The following is a description of a gene set: studied in species Homo sapiens Catalysis of the hydrolysis of any non-peptide carbon-nitrogen bond in a linear amidine, a compound of the form R-C(=NH)-NH2. Human Gene Set: GOMF_HYDROLASE_ACTIVITY_ACTING_ON_CARBON_NITROGEN_BUT_NOT_PEPTIDE_BONDS_IN_LINEAR_AMIDINES, and this is the list of marker genes: DDAH2, ARG1, ARG2 (NCBI Gene Id 384), PADI1, PADI6, DDAH1, PADI3, PADI2, AGMAT, PADI4, ALLC